Given this list of marker genes ACVR1, DCHS1, SOX4, NOTCH1, AXIN2, EFNA1, NAGLU, TWIST1 (twist family bHLH transcription factor 1), ADAMTS19 (NCBI Gene Id 171019), ZFPM1 (zinc finger protein, FOG family member 1), GJA5, BMPR1A, SMAD6, BMPR2, here is a description of the gene set: studied in species Homo sapiens Human Gene Set: GOBP_MITRAL_VALVE_DEVELOPMENT The progression of the mitral valve over time, from its formation to the mature structure.